Given this list of marker genes SLC26A3, PDE4DIP, WASHC2A, SBK1, PTGR3, WSB1, HCK, LACTB, ARL1, UBE2G1, HYCC2, MISP, RPL39, PLXNC1, ALS2, NDFIP2, CTNNB1, POU2AF1, BAIAP3, MTPN, EFNA2, WIPF1, SRSF7, FERMT2, RNF145, ZBTB18, WWTR1, KIAA1191, DAPK1 (death associated protein kinase 1), SERP1, NAA35, LRRTM2, CD72, PLPBP, LCOR, EPS8L1, SUGP2 (NCBI Gene Id 10147, SURP and G-patch domain containing 2), RNPS1, MTERF3, EBAG9, B4GALT6, FHIP2A, ZNF280C, IL2RG, ARHGEF16, ENOPH1, GNB1, KLRD1, TNPO1, ZNF286A, COX18, NFATC3, SLC28A2, FLI1, KIF1B, UBE2D2, SLC46A3, OAT, TSPYL1, RPS21 (NCBI Gene Id 6227), RAP1B, CACNA2D1, AOX1, YY1, QTRT2, GIMAP6, PTGES3, UTP11, ID2, DLX2, MAP3K8, ALDH4A1, VAPA, EDNRB, LGMN, ZFP14, SOX17, SRY, FBXO22, GLRA1, SRSF1, C6orf118, ZFP36L1, NAA30, IARS2, CHD6, PALLD, RTN4, EPS8L3, ETS1 (ETS proto-oncogene 1, transcription factor), VCAM1, ABI3BP, C1S, RCN2, ITGB2, DDX19B, MCL1, CCPG1, CARTPT, SCAF8, LTA4H, COL14A1, GSX1, KBTBD4, HSPA4, FGL2, YES1, SHISA5, ACSS1, ARHGEF3 (NCBI Gene Id 50650), AHRR (aryl hydrocarbon receptor repressor), IGFBP3, LMOD2, FCRL1, NUDT13, CORO6, IL12RB2, PPP1R2P1, SMOC2, TM9SF2, YWHAQ, CDC73, CFLAR, ARL3, HMBOX1, DR1, CYRIB, NFKBIZ, PAWR, PLCG1, MAPK6, ADGRL4, TMEM123 (NCBI Gene Id 114908), HIVEP2, MEP1B, CXCR2, GRIPAP1, ZYG11B, GLI3, CRK, SASH1, CHMP1B, EDEM3, MARCKS, C16orf87, TIMMDC1, USP12, MARK3, RPS15A, AHCYL2, PIK3R4, MYH11, FAIM, TRIM41, DDX5, SERAC1, NEFH, RCN1, FAM149B1, COLEC12, TOMM20, SLC34A1, ELOVL7, ETNK1, TSC1, STXBP3, TRIM17, MAN1A1, STAM2, ERN1, FGD1, TPM3, KMT2E, EHHADH, NIPA2, SCNN1A, CFH, PRSS23, NDFIP1, PAPSS2, ELF1, ZNF23, ALDH6A1, ADCY7, AMACR, SOWAHC, MAP2K1, PROSER1, ARCN1, IGF2R, DDX3Y, GNG10, CD164, PTBP2, DDX6, SMARCD3, ESM1, RHOQ, FNDC1, TMEM267 (NCBI Gene Id 64417), here is a description of the gene set: from publication Hirota K, Yoshitomi H, Hashimoto M, Maeda S, Teradaira S, Sugimoto N, Yamaguchi T, Nomura T, Ito H, Nakamura T, Sakaguchi N, Sakaguchi S (PMID 18025126) Th17 cells are enriched by sorting FR4-CD4+ T cells from SKG mice. A large number of Th17 cells also develop spontaneously when CD4+ T cells from IFN-g-deficient (IFN-g-/-) BALB/c mice are transferred to T cell-deficient RAG2-deficient (RAG2-/-) mice and subjected to homeostatic proliferation, whereas they fail to develop in similar transfer of IL-6-deficient (IL-6-/-) CD4+ T cells to IL-6-/- RAG2-/- mice. To explore the functional molecules specifically expressed by Th17 cells, we conducted Gene Microarray analysis between 10-month-old SKG FR4-CD4+ cells and age-matched BALB/c FR4-CD4+ cells, and between IFN-g-/- CD4+ cells transferred to RAG2-/- mice and IL-6-/- CD4+ T cells transferred to IL-6-/- RAG2-/- mice. The analysis revealed that 1,556 and genes were up-regulated in 10-month-old SKG FR4-CD4+ and IFN-g-/- CD4+ T cells after homeostatic proliferation, respectively, with genes shared by the two groups of genes. The genes included those encoding cytokines, chemokines, and their receptors, such as IL-1 receptor type1 (IL-1R1), IL-17, IL-22, IL-21, CCR6, and CCL20. species: Homo sapiens Human Gene Set: GSE9316_CD4_TCELL_BALBC_VS_TH17_ENRI_CD4_TCELL_SKG_PMA_IONO_STIM_FR4NEG_DN Genes down-regulated in FOLR4- CD4 T cells treated by phorbol myristate acetate and ionomycin from: BALB/c versus SKG mice.